Given this list of marker genes APC, PARD6A, CEP250, BICD1, MARK4, NUP62, GSK3B, here is a description of the gene set: Any process that activates or increases the frequency, rate or extent of protein localization to centrosome. studied in species Homo sapiens Human Gene Set: GOBP_POSITIVE_REGULATION_OF_PROTEIN_LOCALIZATION_TO_CENTROSOME